The following is a description of a gene set: Human Gene Set: GOBP_NEURON_FATE_DETERMINATION The process in which a cell becomes capable of differentiating autonomously into a neuron regardless of its environment; upon determination, the cell fate cannot be reversed. studied in species Homo sapiens, and this is the list of marker genes: NKX2-2, WNT1, CTNNB1, PRRX1, FOXG1, FEZF2, LBX1, PROX1, ATOH1, CDC42